Given this list of marker genes PROKR2, GNAI1, MAPK3, PROK1, MAPK1, GNAI2, PROK2, GNAI3, here is a description of the gene set: Mutation-inactivated PROKR2 to PROK-PRKR-Gi-ERK signaling pathway. Pathway ID: N00881. Pathway type: Variant. Pathway class: nt06361 Hypogonadotropic hypogonadism. studied in species Homo sapiens Pathway Definition from KEGG: PROK1/2 -> PROKR2* -> GNAI -> ERK Human Gene Set: KEGG_MEDICUS_VARIANT_MUTATION_INACTIVATED_PROKR2_TO_PROK_PRKR_GI_ERK_SIGNALING_PATHWAY